Given this list of marker genes CASP10, STAT6, GPC4, IL2RG, DOCK11, CD40, KRT74, EXTL3, IL6ST, FOXP3, WAS, GPC3, NFKBIA, DSG1, FASLG, LCK, DCLRE1C, BTK, ARPC5, CDSN, ADA, IKBKG, POLD3, TOM1, SLC19A1, TGFB1, IRAK4, ZNF341, DOCK8, CD247, IL7R, TCF3, NCKAP1L, IPO8, PDCD1, CD40LG, COL7A1, FAS, KRT9, BACH2, IL21, NSMCE3, IL2RA, PGM3, CARD9, IL6R, SPINK5, ADAM17, CARD10, TYK2, EGFR, STAT5B, STAT3, CARD11, here is a description of the gene set: Abnormal circulating IgE concentration Human Gene Set: HP_ABNORMAL_CIRCULATING_IGE_CONCENTRATION studied in species Homo sapiens An abnormal deviation from normal levels of IgE immunoglobulin in blood.